The following is a description of a gene set: from publication Sato N, Fukushima N, Maitra A, Matsubayashi H, Yeo CJ, Cameron JL, Hruban RH, Goggins M (PMID 12839967) Human Gene Set: SATO_SILENCED_EPIGENETICALLY_IN_PANCREATIC_CANCER genes up-regulated in the pancreatic cancer cell lines (AsPC1, Hs766T, MiaPaCa2, Panc1) but not in the non-neoplastic cells (HPDE) by the combination of decitabine and TSA. studied in species Homo sapiens To identify potential targets for aberrant methylation in pancreatic cancer, we analyzed global changes in gene expression profiles of four pancreatic cancer cell lines after treatment with the demethylating agent 5-aza-2'-deoxycytidine (5Aza-dC) and/or the histone deacetylase inhibitor trichostatin A. A substantial number of genes were induced 5-fold or greater by 5Aza-dC alone (631 transcripts), trichostatin A alone (1196 transcripts), and by treatment with both agents (857 transcripts). Four hundred and seventy-five genes were markedly (>5-fold) induced after 5Aza-dC treatment in pancreatic cancer cell lines but not in a nonneoplastic pancreatic epithelial cell line. The methylation status of 11 of these genes was examined in a panel of 42 pancreatic cancers, and all 11 of these genes were aberrantly methylated in pancreatic cancer but rarely, if any, methylated in 10 normal pancreatic ductal epithelia. These genes include UCHL1 (methylated in 100% of 42 pancreatic cancers), NPTX2 (98%), SARP2 (95%), CLDN5 (93%), reprimo (86%), LHX1 (76%), WNT7A (71%), FOXE1 (69%), TJP2 (64%), CDH3 (19%), and ST14 (10%). Three of these genes (NPTX2, SARP2, and CLDN5) were selected for further analysis in a larger panel of specimens, and aberrant methylation of at least one of these three genes was detectable in 100% of 43 primary pancreatic cancers and in 18 of 24 (75%) pancreatic juice samples obtained from patients with pancreatic cancer. Thus, a substantial number of genes are induced by 5Aza-dC treatment of pancreatic cancer cells, and many of them may represent novel targets for aberrant methylation in pancreatic carcinoma., and this is the list of marker genes: S100P, DDX4, SALL1, FGF2, EZR, AURKC, IL32, MLH1, CRLF1, SGCE, DAPK2 (NCBI Gene Id 23604), NLRP2 (NCBI Gene Id 55655), DAZL, ITM2C, HSPA1A, UCHL1, BIK, GAS1, STAT3, S100A2, CDKN2A, LIPC, PAX6 (paired box 6), SRGN, CASP5, GAGE12F, CDC25A, TP53I11, SFRP1, CCNA1 (cyclin A1, NCBI Gene Id 8900), SPANXC (NCBI Gene Id 64663), MAGEC1, CCN5, BNIP3, WT1-AS, ARC, KRT17 (NCBI Gene Id 5103), XAGE1B, CRIP1, CSF3, CLDN7, TKTL1, BST2, GAGE12G, LHX2, F11R, MMP8